Given this list of marker genes Aqp4, Mbl2, Abca3, Lipa, Picalm, Hamp, Adcy6, Nfat5, Cybrd1, Slc40a1, Lamp3, Tmem63a, Nkiras2, Neo1, Akr1b1, Aqp2, Pthlh, Oas1h, Hjv, Ext1, Mllt6, Oas1f, Trf (transferrin), Epas1, Hmox1, Kdr, Scnn1a, Tfr2, Oas1g, Ireb2, Wfs1, Nkiras1, Hamp2, Naglu, Tgfb1, Bpifa5, Scnn1g, Cftr, Fech, Itgb6, Hephl1 (NCBI Gene Id 244698), Slc11a2, Scnn1b, Tfrc, Aqp1, Oas1a, Aqp3, Atp6v1b1, Trpv4, Oas1d, Sftpd, Oas1e, Ank1, Abca12 (NCBI Gene Id 74591), Ctns, Fbxl5, Avp, Hfe, Bmp6, Hyal2, Fgf7, Slc11a1, Umod, Ctsh, Mbl1, Bpifa1, Rhd, Tmem63b, Aqp7, Pla2g4a, Erbb4 (erb-b2 receptor tyrosine kinase 4), Oas1c, Mir122, Rhag, Mir17, Epb42, Has2, Napsa, Adgrf5, Ext2, Eif2ak1, Oas1b, Aqp6, Akap11, Lpcat1, Heph, Btbd9, Inpp5k, Rcn3, Htt, B2m, Vegfa, Sod2, Sctr, Tmprss6, here is a description of the gene set: Mouse Gene Set: GOBP_MULTICELLULAR_ORGANISMAL_LEVEL_CHEMICAL_HOMEOSTASIS A homeostatic process involved in the maintenance of a steady state level of a chemical within extracellular body fluids, such as blood, xylem or phloem, of a multicellular organism. This is distinct from maintenance of cellular homeostasis, which occurs within a cell. species: Mus musculus